The following is a description of a gene set: from publication Chen Y, Wang X (PMID 31504780) studied in species Homo sapiens Genes predicted to be targets of miRBase v22 microRNA hsa-miR-103a-2-5p in miRDB v6.0 with MirTarget v4 prediction scores > 80 (high confidence targets). Human Gene Set: MIR103A_2_5P, and this is the list of marker genes: NSD1, TCEAL9, CARD8, SLC9A8, SEMA5A, DPYS, SEC24A, CNNM2, ELOVL6, FBXO45, DLL1, PXYLP1, HHLA1, HAUS6, CSTA, EXO1, G3BP1, MCL1, MKRN1, DUSP3, VPS35L, LIFR, SPON1, EOGT, AFF1, ZFP91, LYST, ABCC9, OGG1, CCL23, OPN5, C5orf24, LRATD1, NRXN1, NGEF, RBM27, RGL1, STRIP1, SESN1, GPR82, SPOCK3, MTF2, RALA, MBNL2, LARP4, DYRK1A, SMAD2, HEXIM1, AMMECR1, TMEM200B, FAT3, EIF2AK4, UBE4B, ABL2, IFT80, XIAP, IL36G, NR3C1 (nuclear receptor subfamily 3 group C member 1), CYLD, NRAS, CDK6, LGI2 (leucine rich repeat LGI family member 2), SGCD, MAB21L2, TMEM154, APBB2, RSPO3, SLC28A1, CRACD, ARMH4, TNPO1 (transportin 1), COMMD3-BMI1, MCAT, PPFIA4, RHEB, KPNA7, KMT2A (NCBI Gene Id 79951), SRSF1, UBE2A, BARD1, CDH11, ABHD10, TENM1, EPS8, DAO, DNAAF9 (NCBI Gene Id 348549), PALM2AKAP2, CDH12, CPEB3, TMEM108, ZNF827, RAB31, TBCA, ZHX1, GLO1, LRRC39, EPHA4, MGA, PLXDC2, SYNM, ERVV-1 (endogenous retrovirus group V member 1, envelope), DNAL1, IGF2R, MAGI3, ESR1, BAG4 (BAG cochaperone 4), TAF7, DACH1, SON, CYLC2, FAM174A (family with sequence similarity 174 member A), OXTR, RBAK, MAN2A1, NFXL1, SLC8A1, TMIE, UBR3, ONECUT2, MEF2C, G3BP2, DNM3, MTMR1, ZNF180, VAV3, EPHB1, GXYLT1, ZNF236, RAB21, TNRC6B, LURAP1L, SLC38A2, TRAPPC13, FXR1, MITD1, PLAGL1, LILRB3, SCN2A, HCFC2, MAGI1, SLC46A2, CCPG1, PAK2, JPT1, ATP6V0D1, BBX, BLCAP, ZNF711, ITGA8, KDF1, UST, NAA50 (N-alpha-acetyltransferase 50, NatE catalytic subunit), BCL6B, MOSMO, USP31, CHGB, TADA2B